Given this list of marker genes Ednrb, Edn1, Nfat5, Adm, Akr1b1, Adrb2, Adrb1, Adcy6, Oprl1, Trpv5, Drd2, Nppb, Ptger3, Has2, Umod, Slc4a1, Ptger4, Adora2a, Inpp5k, Gnai2, Oxt, Npr3, Avpr2, Uts2r, Slc5a2, Uts2, Btc, Mllt6, Hyal2, here is a description of the gene set: Mouse Gene Set: GOBP_REGULATION_OF_URINE_VOLUME species: Mus musculus Any process that modulates the amount of urine excreted from the body over a unit of time.